The following is a description of a gene set: Genes containing one or more binding sites for (ZNF239) in their promoter regions (TSS -1000,+100 bp) as identified by GTRD version 20.06 ChIP-seq harmonization. from publication Yevshin I, Sharipov R, Kolmykov S, Kondrakhin Y, Kolpakov F (PMID 30445619) Human Gene Set: ZNF239_TARGET_GENES studied in species Homo sapiens, and this is the list of marker genes: SMG7, SH2B3, JSRP1, BEAN1, CXXC5, MTFR1 (mitochondrial fission regulator 1), TMEM94, ZKSCAN2, NIBAN3, ERCC1, CASC3, DTX1, INTS12, TM7SF2, LRRC59, SEC14L5, NEAT1, GSTCD, SCAND1, MAPT, NCOR2 (NCBI Gene Id 9612), MMP25, MAN1C1, ENSG00000256609, BEAN1-AS1, SH2D5, AP1M1, ADGRG1, RTEL1, ARSG, SMG7-AS1, CNN2, CCN1, ZNF579, STMN3, STAT6, CNBD2, ZDHHC2, SLC16A6